Given this list of marker genes Triap1, Tmem30a, Apoa1, Prelid1, Abcb4 (NCBI Gene Id 18670), Prap1, Fasl (Fas ligand), Atp8a1, Xrcc4, Apoe, Abca7, Abca3, Atp8a2, Dbi, here is a description of the gene set: Any process that activates or increases the frequency, rate or extent of phospholipid transport. Mouse Gene Set: GOBP_POSITIVE_REGULATION_OF_PHOSPHOLIPID_TRANSPORT species: Mus musculus